The following is a description of a gene set: Mouse Gene Set: MIR_346_3P studied in species Mus musculus from publication Chen Y, Wang X (PMID 31504780) Genes predicted to be targets of miRBase v22 microRNA mmu_miR_346_3p in miRDB v6.0 with MirTarget v4 prediction scores > 80 (high confidence targets)., and this is the list of marker genes: Nucb1, Nt5c3b, Ttc23, Mpz, Ewsr1, Mafb (MAF bZIP transcription factor B), Vars2, Egr1, Slc25a14, Jade2, Cyp2ab1, Smyd5, Styxl2, 9930111J21Rik1, Fam120c, Tsc1, Ifrd2, Heph, Foxp4, Vasn, Atg9a, Eeig1, Rimoc1, Dbndd1, Adgra2, Nfasc, Ube2m, Eaf1, Slc25a10, Trappc9, Dgkk, Ubl5b, Syvn1, Gja8 (gap junction protein, alpha 8), Otud5, Arc, Anpep, Efnb2, Cbx5, Casc3, Ddx3x, Cthrc1 (collagen triple helix repeat containing 1), 2510039O18Rik, Nat8l, Agpat1, Gpsm1, Stra6, Btbd9, Atxn7l3, Gprc5b (G protein-coupled receptor, family C, group 5, member B), Susd6, Abcb11, Git2, Pear1, Nptx1, Sfxn5, Cbx6, Vsx2, Gigyf1, Erf, Fbxl20 (NCBI Gene Id 97750), Csdc2, Atg4b, Cd79a, Cldn11, Sptbn2, Eif5a, Rprd1b, Trim46, Rnf44, Zdhhc8, Ubtf, Mdga1, Ndrg1, Cilk1, Cbx7, Tmem132e, Zbtb37, Stard3nl, Ptpru, Sh3kbp1, Atp7b, Lrrc61, Myo1d, Adamts1, Micall1, Abcd1, Tom1l2, Tmem127, Foxo4, Rapgef2, Ttyh3, Zfp710, Dennd10, Plppr2, Epha8, Lingo1, Mecp2, Pbx1, Agap1, Tmem104, Dop1b, Zmym3, Dchs1, Rab43, Tmprss3, Ube2z (ubiquitin-conjugating enzyme E2Z), Col4a2, Rabl3, Capn1, Fxyd6, Sv2a, Hmgb1, Unc45a, Chrm1 (NCBI Gene Id 12669), Hbegf, Sel1l, Mark2, Rgs7bp, Stmn2, Dagla, Or10ad1c, Etf1, Lrp4, Crtc1, Aip, Kcng1, P2rx2, Cbfa2t3, Myrf, Galnt2, Gmip, Hk1, Cacna2d1, Myo1f, Tulp3, Taf9b, Shisa6, Tfe3, Bace1, Slc25a23, Gtdc1, Zc4h2, 1700030J22Rik, Chad, Arid3b, Rap1gap, Bahd1 (NCBI Gene Id 99388), Slc25a46, Itsn1, Ky, Strn, Sarm1, Plxna1, Vangl1, Vangl2, Nfix, Ehd2, Plekho2, Ppp1r1b, Rin3, Tbc1d25 (NCBI Gene Id 52090), Rbbp5, Mindy1, Leng8, Adamts10, Sox10, Nectin1, Atp9b, Grik3, Jph2, Aspm, Zbtb40, Ngef, Cdk16, Fam163b, Stag1, Unk, Disp2, Esrrg, Supt6, Trp73, Itm2c, Zer1, Acap3, Heatr1, Rcvrn, Gse1, Phldb1, Mknk2, Fndc11, Dip2c, Mapk4, Pptc7, Dolpp1, G6pdx, Kif21b, Tspan9, Cks1b, Tubgcp4, 6430548M08Rik, Tln1, Ulk3, Impdh1